The following is a description of a gene set: studied in species Homo sapiens EGF/EGFR signaling Human Gene Set: WP_EGFEGFR_SIGNALING, and this is the list of marker genes: USP8, FOXO1, CREB1, RIN1, MAP3K3, PTPRR, SH3KBP1, MAPK9, HGS, ELK4, CRK, AP2S1, RASA1, USP6NL, CRKL, STAM, CAV2 (caveolin 2), ITCH, MT-CO2, ERRFI1, CDC42, IQGAP1, FOXO4, HRAS (NCBI Gene Id 338029), E2F1, ABL1, PTK2, EIF4EBP1, PCNA, PLD1, PLSCR1, DNM1, MAP2K2, PIAS3, ASAP1, PTPN5, REPS2, NCK1, RAP1A, SH2D2A, RALA, FOSB, PLD2, ERBB2, EGFR, PXDN, CAV1, MAPK8, SHC1, TWIST1, CBL (NCBI Gene Id 867), FOS, STXBP1, AKT1, LIMK2, JAK2, SOS1, CSK, ATXN2, CAMK2A, EGF, SH3GL2, ARHGEF1, VAV2, VAV1, RPS6KA3, RAF1, PAK1, SOS2 (SOS Ras/Rho guanine nucleotide exchange factor 2), MAPK14, RPS6KA2, BCAR1, GRB10, PRKCI, IQSEC1, INPP5D, SRC, PTK6, SYNJ1, AURKA, RAB5A, MAP3K4, RPS6KB1, MEF2C, TNK2, NEDD8, GRB2, NOS3, MAPK4, BRAF, PIK3R1, STAT5B, RALB, EPS8, ROCK1, GJA1, MAP4K1, NCK2, PIK3C2B, CFL1, EPS15, PTPN12, RICTOR, CBLB, PEBP1, RALGDS, GAB2 (NCBI Gene Id 9846), MAPK7, STAT5A, KRAS, RPS6KA5, PDPK1, RALBP1, AP2A1, SP1, PRKCB, PRKCZ, MTOR, STAMBP, JUN, STAT3, AP2B1, JUND, NDUFA13, STAT1, STMN1, STAM2, MAP2K1, NCOA3 (NCBI Gene Id 8202), SH3GL3, JAK1, GAB1, MAP3K2, EPN1, PRKCD, PTK2B, ABI1, INPPL1, EPS15L1 (NCBI Gene Id 58513), RPS6KA1, PLCG1, VAV3, PIK3R2, SPRY2, ARF6, MAP3K1, DOK2, AP2M1, PRKCA, MEF2A, ELK1, MYBL2, MAP2K5, RAC1, ATF1, PTPN11, CBLC, NEDD4, MEF2D, PTEN, MAPK1, PLCE1